The following is a description of a gene set: Reactome Pathway: RHO GTPases Activate NADPH Oxidases species: Homo sapiens part of: RHO GTPase Effectors NADPH oxidases (NOX) are membrane-associated enzymatic complexes that use NADPH as an electon donor to reduce oxygen and produce superoxide (O2-) that serves as a secondary messenger.<p>NOX2 complex consists of CYBB (NOX2), CYBA (p22phox), NCF1 (p47phox), NCF2 (p67phox) and NCF4 (p40ohox). RAC1:GTP binds NOX2 complex in response to VEGF signaling by directly interracting with CYBB and NCF2, leading to enhancement of VEGF-signaling through VEGF receptor VEGFR2, which plays a role in angiogenesis. RAC2:GTP can also activate the NOX2 complex by binding to CYBB and NCF2, leading to production of superoxide in phagosomes of neutrophils which is necessary fo the microbicidal activity of neutrophils.<p>NOX1 complex (composed of NOX1, NOXA1, NOXO1 and CYBA) and NOX3 complex (composed of NOX3, CYBA, NCF1 amd NCF2 or NOXA1) can also be activated by binding to RAC1:GTP to produce superoxide., and this is the list of marker genes: RAC2, MAPK14, S100A8, NCF2, NOXO1, PRKCD, NCF4, S100A9, PRKCB (protein kinase C beta), NOX3 (NCBI Gene Id 57770), PIN1, NOXA1, RAC1, PRKCZ, MAPK1, PIK3C3, PIK3R4 (NCBI Gene Id 30849), CYBA, MAPK3, PRKCA, NCF1, NOX1, CYBB, MAPK11 (NCBI Gene Id 5600)